The following is a description of a gene set: electronically inferred by orthology from the curated human pathway species: Mus musculus This event has been computationally inferred from an event that has been demonstrated in another species.<p>The inference is based on the homology mapping from PANTHER. Briefly, reactions for which all involved PhysicalEntities (in input, output and catalyst) have a mapped orthologue/paralogue (for complexes at least 75% of components must have a mapping) are inferred to the other species. part of: Plasma lipoprotein clearance Reactome Pathway: VLDL clearance, and this is the list of marker genes: Apobr, Apob, Apoc4, Apoc1, Vldlr